Given this list of marker genes Psmd8, Ccl9, C3ar1 (complement component 3a receptor 1), Birc5, Plxdc2, 2310022A10Rik, Nostrin, Epb41, 1110032F04Rik, Rbms3, Endod1, Irf8, Cd68, Soat1, Ppm1l, Crat, Cyp2d41-ps, Heatr1, Calhm2, Plekha4, Jun, Gask1b, Pcdhb17, Tmem132a, Fbxo25, Tulp3, Mafb, Npl, Cnr2, B4galt7, Prrx2, Hic1, Plac8, Pgm1, Synpo, Rps6kc1, Nedd9, Macir, Il17rd, Dok3, Ebp, F2rl1, Tram1l1, Wls, Cd300a, Rasgef1b, Picalm, Cers5, Gusb, Ak1, Gm4919, Lmo2 (LIM domain only 2), Fmc1, Tubb2a, Nrg1, Flt3, St6galnac4, Irag2 (NCBI Gene Id 16970), Fbln2, Scimp, Rtl6, Zranb3, Apol9b, Mthfd2l, Plxnc1, Dram1, Kcnn2, Plat, Gata6, Sema6d, Cd48, Hbs1l, Lrrc27, Ifi27l2b, Cd5l, 4933401L05Rik, Fscn1, B4galt2, BC028528, Uba7, Cpne9, Dusp10, Slc27a3, Ms4a6c, Lgi2, Lrp12, Rab15, Maged2, Colgalt1, Lactb, Klkb1, Micu2, Atp6v1c1, Tnf, Zfp503, Evi2a, Tuba1a (NCBI Gene Id 22142), Tnfsf13b, Bin3, Spaca9, Scly, Foxs1, Smoc2, Tlr13, Lama2, Sulf1, Cotl1, Klf1, Nlrp10, Glrx (glutaredoxin), Dck, Foxp1, Ddah2, Pou3f1, Arhgdia, Ccn4, Gmfg, Tnfaip6, Cfl1, Cyba, Vim (vimentin), Acot10, Col5a1, Arhgap25, Gsdmd, Klhl6, Ccl7, Slc66a2, Tubb5, Plxnb2, Slc35f6, Cdcp2, Arhgap18, Pmaip1, Tgfb3, Armcx2, Zbtb48, Tbpl1, Reep4, Airn, Ttc28, Cd160, Ifnar2, Cfp, Pea15a, Rassf1, Anxa4, Pld4, Ptgr2, Amz1, Ankfy1, Gcnt1, Atp6ap2, Tspan33, Ccr5, Rhoj, Arpc1b (NCBI Gene Id 50737), Clec10a, Ppm1j, Cybb, Ms4a4c, Ap2m1, Etfb, Plcg2, Pfkp, Prr13 (NCBI Gene Id 72100, proline rich 13), Atp6v1b2 (NCBI Gene Id 97492), P2rx4, H2-M3, Haus8 (NCBI Gene Id 76478), Ppl, Nipal3, Slc6a6, Gsn, P3h3, Casp1, Plb1, Tbc1d9, Il18bp, Srd5a3 (steroid 5 alpha-reductase 3), Unc93b1, Azin1, Gba1, Tle4, Plekho1, Slc41a2, Serpina1f, Oxct1 (NCBI Gene Id 67041), Svep1, Susd4, Bach1, Ccl2, Chst12, Ctsk, Gpm6b, Hexb, Card19, Fut7, Ptpn18, Calr, Ikbke, Tk1, Cd44, Layn, Chtf18, Ctss, Ccrl2, Sybu, Irf5, Casp2, S100a11, Tlr2 (toll-like receptor 2), Lrcol1, Alox5ap, Entpd2, Lgals1, Afap1l2, Mpnd, Tmem273 (NCBI Gene Id 70848), Rgs1, Ctsb (NCBI Gene Id 210034), Tceal5, Tubb4a, Trpv2, C8b, Ppp1r14b, Cldn22, Capg, Elovl1, Cbx6, Kif1c, S100a6, Mxra8, Csf3r, Wdr91, Arpc4, Krtap19-5, Acvrl1, Mical2, Rgl1, Cbr3, Tmem106a, Rasl2-9, Rin2, Fgd6, Med11, Peg12, Tmem165 (NCBI Gene Id 21982), Vat1, Havcr2, Rnaseh2b, C1qc, Bgn, Cdkn2c, Skp2 (S-phase kinase-associated protein 2), Wdfy4, Ifit3, Mtfp1, Slc27a6, Txnrd1, Thbs2, Pip5kl1, Slamf6, Lat2, Rab29, Rpe65, Ccdc148, Dpep2, Milr1, Ccna2, Filip1l, Psrc1, Cd9, Cndp2, Pecr, E2f8, Lgr4, Sema4d, H2-DMb1, Plk2, Smc1b, Dysf, Fabp7, Or10al6, Clic1, Apbb1ip, Gmip, Prickle1, Nfam1, 2010001K21Rik, Zfyve26, Cacnb3, Icosl, Stxbp3, Lox, Cybc1, Prodh2, Aopep, Scd2, AU018091, Ifnar1, Fam83f, Nat8f1, Snx24, Fen1, Cd276, Ptk2b, Krt18, Pcna, Gch1, Htra3, Pif1, Capn2, Vipas39, Fam216a, Diaph3, Asf1b, Cyp4f13, Ppic, Pkib, Slamf8, Rilpl2, Hal, Mcm3, Prcp, Blvra, Stard3, Unc13d, Spmip3, Ccdc102a, Trerf1, Unc5b, Atf3, P2ry13, Srpx, Cyfip1, Arhgap15, BC005537, Tmem52b, Pgs1, Agpat4, Vasn, Shtn1, Gipc2, Stab1, Ms4a7, Usp20, Mzt2, Inpp5d, Or51m1, Smox, Slco3a1, Ppm1h, Scnn1a, Themis2, Cygb, Slco2b1, Ubtd1, Myof, Slc35e4, Necab1, Slc2a6, Samhd1, Syk, Chchd7, Sema3b, Map4, Frmd6, Trim30a, Ptpn13, Dusp18, Arhgap45, Pi4k2a, Me2, Palb2, Dpp7, Lilra6, Plin4, Nrbp2, Ttc39c, Slc7a6, Gpr179, 1700037C18Rik, Slc22a7, Cd200r1, A630001G21Rik, Egr2, BC016579, Actg1, Cdk18, Exoc3l4, Olfml3, Mcm5, Tmsb4x, Clcn5, Emp3, Clec7a (C-type lectin domain family 7, member a), Ddx31, Btc, Aph1c, Hycc1, Ccdc3, Fuca2, Prkag3, Tmem202, Dgcr2, B4galt6, 2010003K11Rik, Prmt2, Mapk7, Dcxr, Dbh, Trip13, Sprr1a, Chchd6, Atp6v0c-ps1 (NCBI Gene Id 56326, ATPase, H+ transporting, lysosomal V0 subunit C, pseudogene 1), Nrros, Bicc1, Ddt, Crlf3, Olr1, Mmp23, Actbl2, Atp6v0d2, Dusp5, Vsir, Col6a3, Akr1a1, Auts2, Hk3, Pf4, Abl2, Aif1, Avpr1a, Fmnl3, Tnfrsf18, Comtd1, Lamp2, Cnrip1, Ptchd1, Lonrf3, Epb41l3, Tnc (NCBI Gene Id 21923), Mefv, Laptm5, Atp13a2, Sccpdh, Batf2 (NCBI Gene Id 74481), Btg3, Litaf, Lyl1, Lrrc39, Cystm1, Ecscr, Abr, Tlr7, Ripk3, Slc39a6, Peds1, Rac2, Gpnmb, Epb41l2, Abi2, Lilrb4a, Plgrkt, Pik3ap1, Fetub, Lcp1, L1cam, Msc, Ctla2b, S100a7l2, Aldh18a1, S1pr2, Dock10, Pip4p2, Manba, Colec12, P2ry10b, Cyp2c50, Car13 (carbonic anhydrase 13), Pltp, Ptgir, Opn3, Rab34, Sptan1, Pip4k2a, Gpld1, Serpina11, Spsb2, Hcst, Man1c1, Trem2, Galnt3, Camkk1, Fxyd5, Cachd1, Pld3, F7, St8sia4, Dynll1, Tnip3, P2ry6, Gas8, Tmem229b, Siglecf, Msr1, Hcls1, Hacd4, Batf3, Rasgef1a, Lpcat2, Lgals3bp, Arap1, Zfand2a, Kcne3, Tmem245, Rgs18, Cyp4f16, Asl, Col5a2, Usp43, Adap2, Cdh3, Lmna, Mre11a, Calm3, Drosha, Slc27a5, Prkx, Sp100, Meltf, Cstb, Map3k20, Phf11d, Lrrc25, Rab8b, Srxn1, Cxcl2, Slfn2, Cd84, Slc25a36, Rab7b, Tanc1, Gjb1, Renbp, Rnf207, Cd53, Nfe2l2, Casp12, Trim32, Lacc1, Lilrb4b, H2-DMb2, Col1a1, Flrt2, Pycard, Mdfi, Serpinb9c, Asah1, Rgs14, Slc2a4, Stxbp2 (syntaxin binding protein 2), Phldb1, Rnf122, Rnf217, Mmp12, Tlr4, Ltbp1, Glipr1, F10, Plxnb3 (plexin B3), Ms4a6d, Samsn1, Entpd1, Sestd1, Mtrfr, Tph2, Fn3k, Fam131a, Epsti1, Mthfs, Slc7a8, Sms, Apobec3, Kcnn4, Htra1, Lipa, Cd37, Acot9, Gns, Mogat1, Acy1, Commd10, Dock2, Niban2, Card11, Tmem119, Il10ra, Tpcn2, Ncf2, Ccl6, Itpr3, Fbxo32, Mfrp, Pdgfrb, Gsap, Mpeg1, Ankrd33b, Sat1, Tubb6, Cdc7 (NCBI Gene Id 12545), Hc, Osbpl8 (NCBI Gene Id 319994), Cadm1, Rnh1, Eml1, Abcb4, Clec4d, Atp6v1a, Gss, Clba1 (NCBI Gene Id 320284), Ppib, Fcer1g (Fc receptor, IgE, high affinity I, gamma polypeptide), Rps6ka2, Pkmyt1, Capns2, Scpep1, Panx1, Tnip1, Mmp19, Batf, Ces1d, Tonsl, Rfng, Slpi, Fmn1, Tpd52 (NCBI Gene Id 99538), Cyrib, Rubcnl, Glb1, Adcy6, Apol9a, Acsbg3, Fhl2, Tmem164, Plxdc1, Spred1 (NCBI Gene Id 99293), Cyp2d13, Adgre5, Mthfd1, Ccdc120, Fbln7, Fam111a, Fcgr4, Tfec, Tmprss3, Acer3, Asgr1, Wasf1, Sdr42e1, Twf2, Slc8a1, Ripor1, Syp, Cmtm3, Myl12b, Atad2, Igfbp2 (NCBI Gene Id 98288), Ywhah, Plaur, Armc2, Col14a1, P3h2, Aldh1b1, Pmp22, S1pr5, Hoxd4, Nqo1, Pde3b, Hvcn1, Sstr2, Gnmt, Gpsm3, Rinl, Cyp2d10, Cd244a, Bex3, Dpysl3, Eva1a, Ak8, Inip, 2810025M15Rik, Stx7, Dennd1c, Nckap1l, Usp12, Lyn, Msx2, Clec4a3, Hagh, Dnase1l1, Sesn1, Arl11, Gadd45b (growth arrest and DNA-damage-inducible 45 beta), Myo5a, Cd74, Tgfb1i1, Eci3, Smpdl3a, Prr5l, Cyp2c37, Lgmn, Hpgds, Spred2, Olig2, Mmp3, Pilra, Gdf3, Stxbp1, Cyp2c54, Dna2, Srgn, Tyro3, Slco2a1, Smim5, Ajuba, Nlrc3, Prkcd, Ninj1, Wt1, Cklf, Jtb, Rab19, Tmem86a, Fmod, Mfhas1, Uck2, Ermp1 (NCBI Gene Id 52008), Acp2, Pcdhb21, Snx20 (sorting nexin 20), Lipc, Armc3, Frrs1, Slc31a1, Hmga1, Rgs19, Stambpl1, Cdc42, Cln8, Plekhb2, Stxbp5, Duoxa1, Osbpl3, Mmp27, Blvrb, Anapc13, Evl, Fcgr3, Nin, Lcp2, Fstl4, Col16a1, Tbc1d16, Spout1, Gnb3, Rcn3, Lxn, Pxmp2, Spata6, Yipf7, Emilin1, Rasa4, Flad1, Myo9b, Rab3il1, Slc48a1, Hk2, Pla2g4a, Igsf8, Cxcl14, Abi3, Cdt1, Gpr137b, Ptprc, Slc4a11, Wfs1, Or10p21, Abhd12, Npdc1, Cd14, Myo1e, Ctc1, Sdc2, Fcgr1, Oas1g, Bcl2l13, Mcl1, Art4, Lrig1, Slc43a1, Akr1b8, Agmat, Cdca3, Clcnkb, Serpina1d, Tspan6, Sema5a, Lpxn, Rhbdf1, Syngr1, Ubd, Cidea, Pimreg, Ifi204, Elf3, Rab2a, Inhca, AB124611, Dcdc2c, Map3k8, Acss1, Cidec, F11, Pitpnm1, Ptpro, Abcc4, Pbld2, Ptpn6, Htra2, Eaf1, Ifi27, Cdk15, Stra6l, Tor2a, Arhgdib, Mmp2, Gpr65, Blnk, P2ry14, Sh3bp2, Fam131b, Col1a2, Gnb1, Lair1, Parp8, Cd3e, Cfap96, Fbn1, Kctd17, Il10rb, Lce3b, Slc1a5, Eps8 (NCBI Gene Id 13860), Synj1, Cd38, Prodh, Ace, Gatm, Tnfaip2, Plcd3, Sema3g, Flna, Fam83a, Sptlc2, Phyh, Fes, Slc11a2, Sgpl1, Naip2, Ten1, Kyat1, Mrc1, Ly86, Ear6, Anxa3, Cavin1, Clec1b, Arid3a, Trex1, Bcs1l, Csf1r (colony stimulating factor 1 receptor), Rnf128, Tmem51, Lrrc52, Steap1, Or5p6, Kif22, Spin2c, Nrp2, Bcl2a1b, Zfp90, Tnfaip8, Mpv17l, Obi1, Niban1, Ltbp3, Ifi203, Nlrp6, Hsd3b5, Tec, Postn, Itm2c (NCBI Gene Id 98594), Ms4a6b, Ch25h, Rhoc, Il1rl1, Pilrb1, Ehd4, Vcan, Gdpd1, Aldh3b1, Arl5c, Pirb, Tyrobp, Snn, Ang, Spic, Ptpn1, Spats2l, BC024139, Nfkb2, Cd36, Neurl2, Tm6sf1, Pparg, Tpm3, Ahcy, Tax1bp3, Slc25a23, Csf2rb2 (colony stimulating factor 2 receptor, beta 2, low-affinity (granulocyte-macrophage)), Cytip, Or4d6, Cyp2e1, Gdf10, Dnmt1, Itgax, Surf1, Fshr, Arrb2, Ms4a4d, Rap2b, Il33, Cbfb, Actr3 (ARP3 actin-related protein 3), Fbln5, Cers6, Sirpa, Snx1, S100a8, Otulinl, Snx5, Numbl, Tceal1, Vamp4 (NCBI Gene Id 53330), Cd34, Sphk1 (NCBI Gene Id 66122), Sort1, Mcmbp, Anpep, Slamf7, Arhgap22, Pam, Rcn1, Msantd3, Plekhn1, Fhl1, Bmp8b, Tcaf3, Actl6b, Galns, Man2b1, Ubash3b, Rassf8, C8g, Fos, Atp6v0b, H2-Aa, Cd22, Abcg1, Cyth4, Lhfpl6, Ctsd, Grn, Bcl2a1c, Aak1, Adam19, Anxa2, Cpxm1, Pla2g7, Lpl, Zdhhc6, Stat4, Slc5a4a, Adcy7, Ier5, Ccl3, Mpp3, Psap, Nap1l1, Gpat3, Tep1, Cenpa, Tagln2, Scn11a, Arhgap10, F13a1, Cnmd, Itgbl1, Tifab, Atp1a3, Npc2, Oacyl, Magix, Dnmt3a, Lrsam1, Arhgap9, Slc15a3 (NCBI Gene Id 65221), Gstm1, Tmem144, Cd180, Nid1, Mt3, Serpinb6b, Zfp385b, Slk, Adprh, Apobec1, Fermt3, Oasl2, Ifit2, Itgad, Ptpn22, Cyp4f14, Gne, Frzb, Abcc5, Ss18l2, Itgb2, Slamf9, Sdf2l1, Gal3st1, Loxl1, Gpx7, Dse, Atp8b2, Mfge8, Treh, Hpcal1, Dnajb11, Mfap2 (microfibrillar-associated protein 2), Lasp1, Ankef1, Tbc1d1, Shank1, Slc4a3, Oit3, Fkbp10, Pawr, Pik3ip1, Rasa1, Rhoh, Atp6v0a1 (NCBI Gene Id 11975), Espl1, Gmnn, Ralgds, Ptger2, Mcub, Mtmr11, Vcam1, Dennd4b, Gng12, Mcoln2, Gm5110, Bcl10, Ifi30, Cd274, Smap2, Fzd5, Myadm, Wfdc3, C1qb, Ggt5, Cyp2c70, Csf2ra (NCBI Gene Id 26991), Psd, Or56b34, Ifngr1, Hmox2, Cttnbp2nl (CTTNBP2 N-terminal like), Efemp2, Trpc4, Igfals, Susd3, Txndc15, Ubtd2, Ptpre, Tmem43, Tgfbr2 (transforming growth factor, beta receptor II), Slc2a10, Il11ra1 (NCBI Gene Id 16157), Snx27, Akna, Rdh12, Ripor3, Ncf4, Was, Trub2, Ldlrap1, Mocos, Klc4, Metrnl, Armc7 (armadillo repeat containing 7), Plek, Mmp13, Slc9a9, Ltbp2, Ebi3, Ldhb (lactate dehydrogenase B), Arpc2, Upb1, Cxcl16, Serpinb6a, Pdgfrl, Vtn, Coro1a (coronin, actin binding protein 1A), Ehd2, Bmper, Rassf4, Far1, Ostf1, Gfra4, Pcgf3, Or5p54, Hey1, Cyp2c29, Tm4sf4, Pold4, Clec4a1, Nans, Fads3, Stk10, Vamp8, Myzap, Tril, Col6a1, Dock8, Sdcbp2, Slc25a10, Rpia, Spi1, Ndrg2, Kcnk13, Ica1, Antxr1, Clspn, Bst1, Mtpn, Pdlim4, Wdr1, Pcolce, Matn2, Plscr1, Gpatch3, Nagk (N-acetylglucosamine kinase), Anxa5, Ctsh, Map3k15, Cfap45, Col4a1 (NCBI Gene Id 207132), Lgals3, Bfar, Enah, Vav1, Adss1, Cds1, Ctps1, Nol4l (nucleolar protein 4-like), Cadps2, Cd63, Hoxb2 (NCBI Gene Id 15409), Rnf149, Slc11a1, Padi2, Myl12a, Tpst1, Obsl1 (obscurin-like 1), Dapp1, Vopp1, Tnip2, Fitm1, Nlgn2, Slc25a24, Hexa, Syngr2, Car2, Col8a1, Chst14, Ano6, Itprid2, Oas1a, Ccl4, Cd72, Sh3bgrl3, Cd83, Gpr137, Gpatch2, Igsf6, Slc37a2, Cd86, Cmas, Hilpda, Frmd4a, Krt8, Adgre1, Taok3 (NCBI Gene Id 72857), Cyp4f15, Myo1f, Arhgap4, Lyz1, Srpx2 (NCBI Gene Id 68792), 3300005D01Rik, Adamts2, Stx4a, Rgs10, Praf2, Cercam, Rftn2, Rab11fip5, Pacsin3, Relb, Htr2b, Fkbp1b, Mlana, Nlrc4, Homer3, Gas2l1, Iqgap2, Speg (NCBI Gene Id 98673), Heph, Lyz2, Arpc5 (NCBI Gene Id 67771), Mthfd2, Slc4a7, Ripply3, Chsy1, Adam8, Pkm, Stk24, Ccdc80, Traf5, Slc39a12 (solute carrier family 39 (zinc transporter), member 12), Pacc1 (NCBI Gene Id 98266), Trmt9b, Rgs2, Syngr4, Slc6a8, Sparc, Abca5, Gpx8 (glutathione peroxidase 8 (putative)), Tom1, Lum, Loxl2, Haao, Dock11, Gsta2 (NCBI Gene Id 14858), Dok2, Kng2, Stk17b, Fkbp1a, Rasa3, Rab31, Zfp521, Creg1, Rassf5, Itgal (NCBI Gene Id 16408), Oasl1, Kctd10, Hmces (5-hydroxymethylcytosine (hmC) binding, ES cell specific), Birc7, Plekhm2, Adamts3, Prune1, Wsb2, Spdl1, Gm4760, Tor4a, Ajap1, Rhov, here is a description of the gene set: studied in species Mus musculus Genes forming the macrophage-enriched metabolic network (MEMN) claimed to have a causal relationship with the metabolic syndrom traits. Identifying variations in DNA that increase susceptibility to disease is one of the primary aims of genetic studies using a forward genetics approach. However, identification of disease-susceptibility genes by means of such studies provides limited functional information on how genes lead to disease. In fact, in most cases there is an absence of functional information altogether, preventing a definitive identification of the susceptibility gene or genes. Here we develop an alternative to the classic forward genetics approach for dissecting complex disease traits where, instead of identifying susceptibility genes directly affected by variations in DNA, we identify gene networks that are perturbed by susceptibility loci and that in turn lead to disease. Application of this method to liver and adipose gene expression data generated from a segregating mouse population results in the identification of a macrophage-enriched network supported as having a causal relationship with disease traits associated with metabolic syndrome. Three genes in this network, lipoprotein lipase (Lpl), lactamase beta (Lactb) and protein phosphatase 1-like (Ppm1l), are validated as previously unknown obesity genes, strengthening the association between this network and metabolic disease traits. Our analysis provides direct experimental support that complex traits such as obesity are emergent properties of molecular networks that are modulated by complex genetic loci and environmental factors. from publication Chen Y, Zhu J, Lum PY, Yang X, Pinto S, MacNeil DJ, Zhang C, Lamb J, Edwards S, Sieberts SK, Leonardson A, Castellini LW, Wang S, Champy MF, Zhang B, Emilsson V, Doss S, Ghazalpour A, Horvath S, Drake TA, Lusis AJ, Schadt EE (PMID 18344982) Mouse Gene Set: CHEN_METABOLIC_SYNDROM_NETWORK